Given this list of marker genes ELL, APH1B, SLC25A37, SLC1A2, TIAM2, RAB27A, GLRX, CHST15, RIMS1, LTB4R, BCL2A1, ZSWIM2, C5AR1, RHOH, RUSC1-AS1, KLHL2, ITGB8, CDC42EP5, TAOK1, LINC00691, CTSB, RAB13, DUSP4, SOD2, GNAI2, CDC6, TFDP2, NAMPT, AQP9, IRS2, VDR, TNFAIP6, PDE4C, GDI1, AICDA, MAP3K4 (mitogen-activated protein kinase kinase kinase 4), CCDC69, METRNL (NCBI Gene Id 653506), RUNX1, STX5, IL1B, H2BC4, UNC79, SEMA4C, LSS, INSIG2, AGPAT4, SLAMF1, ANO3 (anoctamin 3), ANKRD13D, CFAP99, CCND3 (cyclin D3), NKG7, RFTN1, DDIT4, CNTN5, STXBP2, NUCB1 (nucleobindin 1), TNFRSF1B, MLKL, SESN2, SSBP3-AS1, CXCL2, RABGEF1, PLSCR3, MYO1G, TRAF3IP2, PHF1 (NCBI Gene Id 5252), RIPOR2 (RHO family interacting cell polarization regulator 2), HLX, PTGES, CERS5, IL3RA, GABRA6, SIK3, MYL12B (NCBI Gene Id 103910), FLRT3, TBC1D8, NKX3-1, DHX9-AS1, CD55, TNFAIP3, HBEGF, MIR3945HG, RPH3A, RASSF5, USF3, TOM1, MYH8, TREM1, FANCA, ST6GALNAC2, FTH1, CASP4, FJX1, CCDC83, MUCL1, ZBTB17, CGA, BTG1, SERPINB7, MTF1, SH3PXD2B, ZFPM2, PECR, KREMEN1, RIN3, CYTIP, VCAM1, MYL6B, SGSH, MYL6, CSRNP1, TRAF1, TMEM71, LMCD1, SLA, PFKFB3, EXOC7, ST20-AS1 (NCBI Gene Id 283687), LINC01115, PET100, ENSG00000274253, LIMK2, SAXO1, C1QTNF1, SLC49A4, H2BC8, PLAC8, HES1, TMEM234, GMFG, GNG2, HRH1 (NCBI Gene Id 3269), WIF1, SORCS1, NMNAT2, NTS, CD177, IL2RA, PNPLA6, SMOX, H2BC9, CDKN2D, SEPTIN6, HSPA1A, CPTP, PAG1, FIGNL1, ZNF44, HAS1, DUSP18, IER5 (immediate early response 5), ARL8A, AGFG1, PLEKHS1, FGD3, GCH1, MAP3K5, MCEMP1, DACH1, TRIP10, ZNF587, SLC24A4, WDR88, H1-2, FIGN, UBE2B, LINC02092, ITM2C, ZNF577, ST3GAL2, LRRC31, LIPJ, PTGS2, H2AC14, GK5, PLAUR, ARID5B, EMP2, TGFA, CYP3A43, RAMP1, H2BC5, MTHFS, TNIP3, EOLA2-DT, ATP13A3-DT, ZFYVE27, NEFH, RILPL2, here is a description of the gene set: Genes up-regulated in STAT5 double knock-in T cells: control versus IL2 stimulation for 17h. studied in species Homo sapiens from publication Lin JX, Li P, Liu D, Jin HT, He J, Ata Ur Rasheed M, Rochman Y, Wang L, Cui K, Liu C, Kelsall BL, Ahmed R, Leonard WJ (PMID 22520852) Human Gene Set: GSE36888_UNTREATED_VS_IL2_TREATED_STAT5_AB_KNOCKIN_TCELL_17H_UP Cytokine-activated STAT proteins dimerize and bind to high-affinity motifs, and N-terminal domain-mediated oligomerization of dimers allows tetramer formation and binding to low-affinity tandem motifs, but the functions of dimers versus tetramers are unknown. We generated Stat5a and Stat5b double knock-in (DKI) N-domain mutant mice that form dimers but not tetramers, identified cytokine-regulated genes whose expression required STAT5 tetramers, and defined consensus motifs for dimers versus tetramers. Whereas Stat5- deficient mice exhibited perinatal lethality, DKI mice were viable, indicating that STAT5 dimers were sufficient for survival. Nevertheless, STAT5 DKI mice had fewer CD4+CD25+ T cells, NK cells, and CD8+ T cells, with impaired cytokine-induced proliferation and homeostatic proliferation of CD8+ T cells. DKI CD8+ T cell proliferation following viral infection was diminished and DKI Treg cells did not efficiently control colitis. Thus, tetramerization of STAT5 is dispensable for survival but is critical for cytokine responses and normal immune function.